Given this list of marker genes C18orf21P1, TUFM, LINC01515, HNRNPH2, STX1B, ASIC2, UIMC1, SNORD14D, TTLL9, ODF2L, MYADM, ASPSCR1, ZNF566, TRO, CTCFL, RNF128, BCAR3, SACS, KLHL4, LINC03060, ATXN10, DAGLB, PIH1D1, SLC35A3, CRACD, ATP5PB, FLVCR1, ENTPD7, OCIAD1, NR4A1, TMPRSS2 (transmembrane serine protease 2), LIX1L, BCR, MYO18B (myosin XVIIIB), SPACA7BP, RAB14, EZR, UBE2E2, CYTOR, RPSAP12, FUZ, MYEOV, MIR4672, CENPA, PSG2, PFDN5, RUNDC3A-AS1, GAREM2, FBXO46 (NCBI Gene Id 23403), MTCO1P53, CZIB, RRAGD, LINC01063, EXOC1L, PMP22, STOML1, LRRC71, MT-TE, ZNF304, ITGB3BP, ACOT7, LINC00575, SEMA6D, TMCC3, STIM1, RPS27P14, ATP9B, AHI1 (Abelson helper integration site 1), FNDC1 (NCBI Gene Id 84624), ROCK1P1, HABP2, WNT8A, SNX17, PRIM1, CEP44, PDE1B, ACHE, IGLV1-47, FNDC3A, RWDD4P1, PPP2R5B, SNCAIP, LCORL, DDX55, FKBP3, DCLK2, CLIC5, HDLBP, ZNF696, EXOSC8, SLC41A1, PARP3, TNFRSF8 (NCBI Gene Id 943), SSB, IGHE, ZNF331, LRRC32, RPL26P27 (NCBI Gene Id 100271471), CDC37, ARMC10, PRR19, CCDC33, VPS29, GPD1L, CFAP251, GPC5, MT-TT, CSGALNACT1, EFCAB7, H3P14, PTGR1, DNAI1, PRRT3, ADRB1, FLVCR1-DT, LNC-LBCS, TBCB, CFTR, NUS1P1, BID, ATP2A1, P2RX2, DEFA8P, BMP3, ABCC5-AS1, BRPF3, ELOVL2-AS1, SRSF1, NEPRO-AS1, GHR, LINC02205, XPO1, MPP2, GPI, TRAPPC2B, WRAP53, PCDH10-DT, CXXC1, TBC1D1, RAB11FIP4, MIR378D1, SAP130, NELFB, ALKBH2, H1-9P, IPO4, SNHG15 (NCBI Gene Id 285958), RAD54L, PIK3R2, RTF2, KIF19BP, RRP9, MAST2 (microtubule associated serine/threonine kinase 2), TMEM14A, ENSG00000229962, TP53I3, EIF4EBP2P2, LZTR1, EP300, SFT2D2, ENSG00000265445, BMPR1A, ADGRD2, CNN3-DT, C10orf95-AS1, SMAP2, PLD3, CNPY1, NAA20, MAP7, BCAT2, SNORD14E, ARHGAP45, GALK2, RAD23B, LINC00624, EHHADH-AS1, CITED2, ZNF514, AHDC1, MIR4716, MCUB, CTNNBIP1, IFT122, AKT1, KIAA1549, REEP3, ULBP2, RNU6-859P, ISG20, LEPROTL1, DGKZ, ZNF566-AS1, RHPN1-AS1, LINC00472, HS1BP3, NECTIN4, ING2-DT, ZNF2, BRSK2, VCF1, ATP6V0B, ENC1, LINC02029, ASB2, USP47, ZNF382, MYO5C, PLK3, ZNF202, CLEC5A, VAMP1, SLC25A32, PIK3R1, HSPA8, DCAF13, EHBP1L1, MED15, C4orf46, IL4I1, MBD4, BTNL9, PCLAF, VGLL4, MASP2, PRRT4, ENSG00000232995, WIPF2, SLC8A2, CACNB2, DALRD3, CYP20A1, CIT, CLEC3B, FER, SHCBP1L, MON2, B4GALT6, TFAP2A, ACTL6A, CDKL5, PTPRN2 (NCBI Gene Id 5799), MTERF4, LY6G6E, TXNRD1, FEZF2, ZNF337, FBXO8, HIBADH, SNX15, ENSG00000223834, ANKRD19P, SEC13, POLD2, CDC14B, ZBTB43 (zinc finger and BTB domain containing 43), NUP188, MT-ND6, CREBZF, IRX4, RNA5SP179, ZNF827 (zinc finger protein 827), ALG5, GANAB, FNDC10, LINC02288, SMPD5, RABGAP1L, MIR9-2HG, SOX1, EXO5-DT, H3C9P, RHOXF1P3, ELAVL2, IRF2BP2, NKX6-2, ZNF547, ENSG00000221345, KCNH2, NDUFAF3, CYREN, PDCD11, LARS1, RNF38, A1BG-AS1, FOXJ3, RN7SL32P, NHSL3, IRS2, RNU6-237P, WT1-AS, MAP3K7CL, MTCO3P12, ESPN, RNH1, SGPL1, MIR17HG, NDRG4, TTLL5, ALG1L1P, LCA5, H3P36, MIR4453HG, MRPS9, MIR3123, NDUFAB1 (NCBI Gene Id 4706), GJD3 (gap junction protein delta 3), ZNF559, EIF5A2, GALNT6, ANKRD20A5P, BTBD2, GARNL3, TTC17, ENSG00000207407, USP39, WDR55, BHLHE40 (NCBI Gene Id 8553), SLC66A1LP, ZNF559-ZNF177, SIM1, YPEL5, ELOVL2, MAD1L1, INTS13, AP5Z1, MRPL20P1, ACADL, LZTS2, ZNF329, HLA-DRB1, LINC02846, MESTIT1, MSS51, LINC00368, ACBD3, LCN8, ARL4A, USP2, LINC01142, WEE1, CFAP298, KIAA1586, WNT2B, SCAMP3, ARHGEF17, ATP5MK, MRPS18A, STK32C, VDAC1, C1QTNF1, ZKSCAN2, PEMT (phosphatidylethanolamine N-methyltransferase), SLC48A1, DLST (dihydrolipoamide S-succinyltransferase), MIR3195, LY6H, PHACTR4, UBE2E2-DT, ATP6V1G1, SPG11, ANGEL1, PIGZ, ZNF442, BICDL3P, RAD9B, POMK, DIP2A, TULP3, MRPS21, PROX1-AS1, LINC00665, PPIAP44, SMAD3, LMO2, PSMA1, PEX5, SLC4A8, C10orf95, STK40, DNAH14, ASAH1, WASHC3, GPC1, CD99L2, LINC02266, ENSG00000230960, LINC03047, ZNF667-AS1, ARID3B, DKKL1, MAP7D1, GABARAPL2, TMEM130, GABARAPL1, CERNA1, NEU1, THUMPD3-AS1, SLC2A11, RNA5SP89, WDR77 (WD repeat domain 77), TRAPPC3, CFAP96, TP53, CCDC159, XG, BMS1, FGD5, PLS1, AHI1-DT, PPM1L, GTPBP10 (GTP binding protein 10), VGLL3, ERCC1, FGFR1OP2, PPFIA3, PPM1L-DT, ZNF667, ZDHHC8, GNB5, EML6, SLC25A23, PER1, IRX3, DAPP1, TRMT10B, CCDC144CP, GTPBP3, PROX1, IFIT2, RNU6-7, SCART1, RGS5, GPR108, VAMP8, PFN4, SCD, CH25H, ZNF687-AS1, BIN1, SCIN, NPM2, LIPT2, ABCA2, KNCN, KCNJ15, DDIT4, MEST, TRAPPC12, ALDH1A2, PPM1F, SETD5, PCDHAC1, LY6K, DNAJB2, GPHN, PLEKHB2P1, RECK, CIAO1, MRPL55, TRAPPC1, HSPA13, TUSC2, POLR2I, NFIX, ZNF195, TMEM14B-DT, PXN, BORCS7-ASMT, SH3RF3-AS1, EXTL2, RPL14P3, LARGE-IT1, TMED8, KRT18, KANK4, MKLN1, CD58, PGBD5 (NCBI Gene Id 79605), CRHR1, CASP8, HLA-DMA, PHLDA3, ME2, CTNNA1, NR1D1, TMCO3, MTNAP1, TBL3, PEBP1, SLC35F6, LPCAT3, PARP12, NEPRO (nucleolus and neural progenitor protein), GANC, SCAMP1, SRCAP, RNU6-726P, RN7SL698P, DIRAS2, IQCN, HSPA7, SH2B1, UXS1, ARF3, SLC9A3-AS1, LINC01173, INPP5D (inositol polyphosphate-5-phosphatase D), ZNF346, CZIB-DT, CGB7, RSPO1, TNFRSF14-AS1, APAF1, C19orf73, FAM83F, SSTR5, MIR4766, ZNF221, ING2, CCDC83, ARMC7, PPP1R37, DAW1, MFSD12, GRWD1, LGR5, TRAF2, TBX2-AS1, KCNJ11, ECEL1P1, CNTROB, PDCL3P6, MNT, CRTC3-AS1, WASL, GOLPH3L, ADRA1B, CDC6, HES2, RAVER2, TBC1D16, SKIC8, ZNF224, PYGL, NRTN, PDCL2, ETFDH, SLC4A5, TMEM14B, CACNA1G, NIT1, NYAP1, NOL4 (nucleolar protein 4), RFX1, SCAMP1-AS1 (NCBI Gene Id 730815), ATG5, SSTR5-AS1, NT5C1A, NR2F2-AS1, LY6G6D, NANOS1, HELZ, ZNF687, EIF2B4, FBXW7, RIMS3, COL14A1, TAMALIN, ATG16L2, VPS36, RAPGEF3, PKM, CASP8AP2, CFAP298-TCP10L, KCNQ5, GULP1, EXO5, COL8A2, ASB13, GET1, NUF2, IRGQ, SAMD15, ARHGAP12, LATS1, CDC42BPA, NHSL2, LINC02453, DLX4, ZBTB12BP, BRF2 (BRF2 RNA polymerase III transcription initiation factor subunit), B4GALNT1, STK24, QSOX1, SLC2A5, RPL10P2, CHCHD6, ATP6V0A1, ARL5C, LINC01596, BCAR1, FANCM, RASL11A, UROS, EEF1A1P18, LTBP4 (latent transforming growth factor beta binding protein 4), ZNF833P, MIR6080, SMIM27, DHDH, TOMM20, ITGB3, PAEPP1, LSR, FAM228B, CNN3, TPBG, RNU4-2, LRP3, ARHGAP4, ZNF823, BLM, PDE3B, ASAH1-AS1, HNF4A-AS1, MTND5P11, TLCD3B, KCNK1, HSD17B6, FAM135A, NPNT, ZNF865, ZKSCAN2-DT, FOLH1, CRTC2 (CREB regulated transcription coactivator 2), PAX6, METRN, GFUS, SH3BP5, LOXL1-AS1 (NCBI Gene Id 100292820), VOPP1, DCUN1D2, KDELR2, P2RX4, PRDM15, AVPR1A, IFFO1, GGCX, STK11IP, ST8SIA6, BORCS7, here is a description of the gene set: Genes containing one or more binding sites for (ZNF563) in their promoter regions (TSS -1000,+100 bp) as identified by GTRD version 20.06 ChIP-seq harmonization. Human Gene Set: ZNF563_TARGET_GENES from publication Yevshin I, Sharipov R, Kolmykov S, Kondrakhin Y, Kolpakov F (PMID 30445619) species: Homo sapiens